The following is a description of a gene set: Mouse Gene Set: GOBP_REGULATION_OF_ENDOCYTOSIS Any process that modulates the frequency, rate or extent of endocytosis. studied in species Mus musculus, and this is the list of marker genes: Neu3, Ap2a1, Il2rg (NCBI Gene Id 16186), Hip1r, Syt11, Csk, Pard3, Siglecf, Syt17, Amph, Aak1, Tgm2, Usp46, Mbl2 (NCBI Gene Id 17195), Rubcn, Magi2, F2rl1, Lrsam1, Sele, Hmgb1, Nr1h2, Axl, Rack1, Tamalin, Ankrd13a, Calr, Actb, Hap1, Sod1, Rspo1, Ccl21a, Syt4, Mex3b, Lpar1, B2m, Bcr, Ppt1, Cd300a, Abca7, Nckap1l, Ckap5, Unc119, Rab27a (NCBI Gene Id 75673), Cd209b, Prtn3, Pld2, Cd2ap, Vtn, Rab4b, Vamp8, Itgb3, Iqsec1, Appl1, Wnt3a, Bin1, Plk2, Il2rb, Akap5, Apoc1, Tnk2, Lrrtm2, Tbc1d5, Stap1, Atg3, Apela, Lman2, Wdr54, Cav1, Fcgr1, Colec10, Itgav, Sh3gl2, Rock1, Ush1g, Lrpap1, Add1, Ighg2b, Ighg1, Apoa2, Cln3, Sftpa1, Cd47, Dnajc6, Lrp1, Cnn2, Sh3gl3, Egf, Ldlrap1, Camk1d, Dll1, Ankrd13b, Sirt2, Arc, Abr, Tsc2, Cbll1, Adipoq, Myh9, C2, Cdh13, Dock2, Park7, Atad1, Smap1 (NCBI Gene Id 98366), Rac1, Nsf, Ptk2, Itga2 (integrin alpha 2), Drd3, Ntf3, H1f1, Tsg101, Rab5c, Snx33, Rit2, Vamp4, Nrg1, Fcer1g, Bmp2k, Drd2, Cblb, Hamp2, Btbd9, Bcl2l1, Abca13, Snx9, Rufy1, Snph, App, Plscr1, Efnb2, Lrrk2, Il4, Letmd1, Mff, Nedd4l, Gpc3, Ahi1, Mertk, Pip4p2, Ptx3, Cd151, Ank3, Sgip1, Ncdn, Colec11, Dkk1, Atg5, Appl2, Hpca, Prkn, Siglece, Dtnbp1, Cd300lf, Vegfa, Ppp3cc, C3, Cxadr, Mbl1, Dgkq, Sphk1, Cd63, Cd14, Mkln1, Ager, Tspan7, Arpc3, Alox15, Apoc2l, Clu (NCBI Gene Id 28201), Napb, Apoc2, Fpr-rs7, Arrb1, Vps28, Dab2, Prkca, Pacsin3, Serpine1, Btk, Eef2k, Fcgr3, Ahsg, Pip5k1c, Ptpn1, Aplnr, Ighm, Hnrnpk, Dysf, Dlg4, Clec7a, Ophn1, Ptprj, Pllp, Kif3a, Pacsin2, Scarb1, Cd36, Nr1h3, Hamp (hepcidin antimicrobial peptide), Angpt1, Actg1, Rab21, Trf, Snap91, Alms1, Arap1, Ptpn5, Nod2, Fcgr2b, Wasl, Rap1a, Snca, Lrrtm1, Hip1, Pcsk9, Mtmr2, Scamp5, Sftpd, Arhgap21, Fpr-rs6, Picalm, Ccl2, Numb, Arf1, Snx3, Il15ra, Nedd4, Ano6, Synj1 (NCBI Gene Id 77939), Cd177, Slc17a7, Rab4a, Sfrp4, Abca2, Apoc3, Itsn1, Pacsin1, Ap2b1, Vac14, Rin3, Hspa8, Ankrd13d, Sirpa (signal-regulatory protein alpha), Gsg1l, Lgals3, Snx12, Cyba, Cd22, Sdcbp, Trem2, Tub, Fpr-rs3, Plcg2, Ppp3r1, Lyar, Bicd1 (BICD cargo adaptor 1), Rab31, Atg7, Ppp3cb, Rabgef1, Ifng, Actn4, Fmr1, Mctp1, Arrb2, Ppp3ca, Wnt5a, Epn2, Fpr-rs4 (formyl peptide receptor, related sequence 4), Syk, Pick1 (NCBI Gene Id 18693), Tor1a, Ptprc, Pot1b, Apoe, Flot1, Rnf216, Ankfy1, Rnf220, Sirpb1a, Smpd1, Necab2, Insr, Il15, Sh3gl1, Mib1, Atxn2, Myo18a, Ccdc32 (coiled-coil domain containing 32), Dcx, Susd4, Ccl19, Dnm1, Fpr2, Epha3, Hck, Pparg, Ston2, Lbp (lipopolysaccharide binding protein), Lrp2, Ston1, Cbl, Nlgn1, Ubqln2, Cdc42, Rabep1, Syt7, Kcnc3, Hfe, Pros1, Stx1b, Arfgap1, Cfp, Rab5b, Rapgef1, Dnm1l, Slc11a1, Fcnb, Dgkd, Mdm2, Gas6, Anxa2, Apoa1, Tlr2, Itgb1 (NCBI Gene Id 70812), Prom2, Prkcg, Pycard (PYD and CARD domain containing), Fgr, Pten, Ehd4, Tfr2, Scrib, Tgfb1, Src, Apln, Caly, Pla2g5, Drd4, Synj2bp, Rala, Cav3, Dnm2, Ccr7, Tulp1, Clip3, Gata2, Rap1gap, Grem1, Ap2m1